The following is a description of a gene set: Mouse Gene Set: GOBP_NEGATIVE_REGULATION_OF_MYOTUBE_DIFFERENTIATION Any process that decreases the frequency, rate or extent of myotube differentiation. Myotube differentiation is the process in which a relatively unspecialized cell acquires specialized features of a myotube cell. Myotubes are multinucleated cells that are formed when proliferating myoblasts exit the cell cycle, differentiate and fuse. studied in species Mus musculus, and this is the list of marker genes: Bdnf, Xbp1, Csf1r (colony stimulating factor 1 receptor), Ankrd2, Tmem119 (NCBI Gene Id 231633), Hdac4, Bhlha15, Daxx, Ccn3, Nkx2-5, Myocd, Trim72, Plpp7, Bhlhe41, Notch1, Hdac5, Rpl3l